Given this list of marker genes Cln3, Anxa7, Grik3, Gria1, Plp1, Grik2, F2, Ffar2, Gria4, Gria2, Stim1, Grin2d, Nrxn1, Grin1, Atp1a3, Cdk5r1, Grik5, Dlg4, Trpc1, Adrb2, Grin3a, App, Grik1, Ptk2b, Gria3, Camk2a, F2rl2, Grin2c, Grin2b (glutamate receptor, ionotropic, NMDA2B (epsilon 2)), Mef2c, Htr3b, Chrm3, Gna11, Grin2a, Htr3a, Itpr1, Gnaq, Cpeb4, Kalrn, Ffar1, Gm527, Grin3b, Orai1, Plcb1, Tiam1, here is a description of the gene set: The series of molecular signals initiated by activation of a ligand-gated ion channel on the surface of a cell. The pathway begins with binding of an extracellular ligand to a ligand-gated ion channel and ends with a molecular function that directly regulates a downstream cellular process, e.g. transcription. species: Mus musculus Mouse Gene Set: GOBP_LIGAND_GATED_ION_CHANNEL_SIGNALING_PATHWAY